Given this list of marker genes ANPEP, FGF1, KDR, TNFSF12, CXCL8, VEGFC, IL18 (NCBI Gene Id 3606), VEGFD (NCBI Gene Id 2277), EPAS1 (endothelial PAS domain protein 1), MMP19, TNFAIP2, JAG1, NRG1, TBXT, ANGPT1, FGF2, FGF6, here is a description of the gene set: studied in species Homo sapiens Genes in the cancer module 178. Human Gene Set: MODULE_178